The following is a description of a gene set: from publication Chen Y, Wang X (PMID 31504780) species: Mus musculus Mouse Gene Set: MIR_207 Genes predicted to be targets of miRBase v22 microRNA mmu_miR_207 in miRDB v6.0 with MirTarget v4 prediction scores > 80 (high confidence targets)., and this is the list of marker genes: Crebzf, Chmp1b2, Alg9, Arpc5l, Mgat3, Rhbdl3, G3bp2, Erc2, Prdx6b, Dnajc13, Tmem150a, Shisa7, Api5, Fgfr2, Casq2, Akt3, Atxn7, Agtrap, Zkscan17, Rad54b, Ptcd3, Alkbh6, Gfra2, Mtus2, Sh3tc2, Mfsd4b5, Snap29, Agap3, Vamp1 (NCBI Gene Id 78668), Fxr1, Tollip, Tmtc1, Cplx2, BC005537, Phactr3 (phosphatase and actin regulator 3), Slc4a10, Adora2b (adenosine A2b receptor), Mecp2, Npr1, Scfd2, Adgrf5, AI593442, Frk, Pigr, Zfp870, Fndc9, Fat2, Clmp, 9130008F23Rik, Cenpa, Slc10a5, Pold3, Fbxw11, Zcchc18, Eid1, Ptger2, Paip2b, Tcerg1, Rab3c, Tmem30a, Kcnd3, Dbndd2, Cacna1c, Zfp120, Tm9sf3, Styxl2 (NCBI Gene Id 640366), Kdm7a, Gcn1, Pappa, Tln2, Ntrk2, Casp7, Cnot6l, Ehd4, Gli2, Aak1, Traf2, Taf5l, Fmn1 (formin 1), Ankmy2, Derl1, Lpgat1, Etf1, Kcna4, Syndig1, Itsn1, Utp15 (UTP15 small subunit processome component), Lamtor1, Nab1, Emp2, Arx, Tcf15, Fbxo45, Nectin1, Eef2k, Chchd3, Fxyd6, Pabir2, Naa50, Csf3r, Ccdc61, Nfat5, Cd36, Igf1, Syvn1, Pax9, Zfp111, Hivep2, Slc2a12, Slc24a2, Perp, Mpped1, Slc17a8, Fyttd1, Grik3